Given this list of marker genes PRDX2, NNAT, GNB1, HOXC8, GFER, here is a description of the gene set: Human Gene Set: CASTELLANO_HRAS_TARGETS_UP We characterized differential gene expression profiles of fibroblast cell lines harboring single or double-homozygous null mutations in H-ras and N-ras. Whereas the expression level of the individual H-, N- and K-ras genes appeared unaffected by the presence or absence of the other ras loci, significant differences were observed between the expression profiles of cells missing N-ras and/or H-ras. Absence of N-ras produced much stronger effects than absence of H-ras over the profile of the cellular transcriptome. N-ras(-/-) and H-ras(-/-) fibroblasts displayed rather antagonistic expression profiles and the transcriptome of H-ras(-/-) cells was significantly closer to that of wild-type fibroblasts than to that of N-ras(-/-) cells. Classifying all differentially expressed genes into functional categories suggested specific roles for H-Ras and N-Ras. It was particularly striking in N-ras(-/-) cells the upregulation of a remarkable number of immunity-related genes, as well as of several loci involved in apoptosis. Reverse-phase protein array assays demonstrated in the same N-ras(-/-) cells the overexpression and nuclear migration of tyrosine phosphorylated signal transducer and activator of transcription 1 (Stat1) which was concomitant with transcriptional activation mediated by interferon-stimulated response elements. Significantly enhanced numbers of apoptotic cells were also detected in cultures of N-ras(-/-) cells. Our data support the notion that different Ras isoforms play functionally distinct cellular roles and indicate that N-Ras is significantly involved in immune modulation/host defense and apoptotic responses. from publication Castellano E, De Las Rivas J, Guerrero C, Santos E (PMID 16909116) Genes up-regulated in MEF cells (embryonic fibroblast) isolated from HRAS knockout mice. species: Mus musculus